Given this list of marker genes N6amt1, Prmt7, Smyd3, Prmt6, Prdm9, Prmt5, Prmt9, Prmt1, Ndufaf7, Kmt5c, Smyd5, Prdm6, Nsd1, Kmt5a, Carm1, Setd4, Prmt8, Prmt2, Kmt5b, here is a description of the gene set: Mouse Gene Set: GOMF_HISTONE_H4_METHYLTRANSFERASE_ACTIVITY studied in species Mus musculus Catalysis of the reaction: Catalysis of the reaction: S-adenosyl-L-methionine + a histone H4 = S-adenosyl-L-homocysteine + a methylated histone H4. Histone methylation generally occurs on either an arginine or a lysine residue.